Given this list of marker genes Egr2 (NCBI Gene Id 13654), Hoxa2, Zic3, Zic2, Mafb, here is a description of the gene set: Mouse Gene Set: GOBP_CENTRAL_NERVOUS_SYSTEM_SEGMENTATION Division of the central nervous system into a series of semi-repetitive parts or segments. studied in species Mus musculus